The following is a description of a gene set: One-third of all estrogen receptor (ER)-positive breast tumors treated with endocrine therapy fail to respond, and the remainder is likely to relapse in the future. Almost all data on endocrine resistance has been obtained in models of invasive ductal carcinoma (IDC). However, invasive lobular carcinomas (ILC) comprise up to 15% of newly diagnosed invasive breast cancers each year and, whereas the incidence of IDC has remained relatively constant during the last 20 years, the prevalence of ILC continues to increase among postmenopausal women. We report a new model of Tamoxifen (TAM)-resistant invasive lobular breast carcinoma cells that provides novel insights into the molecular mechanisms of endocrine resistance. SUM44 cells express ER and are sensitive to the growth inhibitory effects of antiestrogens. Selection for resistance to 4-hydroxytamoxifen led to the development of the SUM44/LCCTam cell line, which exhibits decreased expression of ERalpha and increased expression of the estrogen-related receptor gamma (ERRgamma). Knockdown of ERRgamma in SUM44/LCCTam cells by siRNA restores TAM sensitivity, and overexpression of ERRgamma blocks the growth-inhibitory effects of TAM in SUM44 and MDA-MB-134 VI lobular breast cancer cells. ERRgamma-driven transcription is also increased in SUM44/LCCTam, and inhibition of activator protein 1 (AP1) can restore or enhance TAM sensitivity. These data support a role for ERRgamma/AP1 signaling in the development of TAM resistance and suggest that expression of ERRgamma may be a marker of poor TAM response. from publication Riggins RB, Lan JP, Zhu Y, Klimach U, Zwart A, Cavalli LR, Haddad BR, Chen L, Gong T, Xuan J, Ethier SP, Clarke R (PMID 18974135) Genes down-regulated SUM44/LCCTam cells (breast cancer) resistant to 4-hydroxytamoxifen relative to the parental SUM44 cells sensitive to the drug. species: Homo sapiens Human Gene Set: RIGGINS_TAMOXIFEN_RESISTANCE_DN, and this is the list of marker genes: MUC1, AOPEP, ZNF148, TNFSF10, PDE10A, NT5DC2, IFI6, SATB2, PMAIP1, UGT1A10, KIF5C, DDX60, ATP8A2, PEG10, UBXN4, LTBP3, CISH, TIMP1, DSP, ADAM9, IFIH1, PLEKHB1, CD47, CLUAP1, INSIG2, ADAM10, TM4SF1, SLC5A3, OAS1 (2'-5'-oligoadenylate synthetase 1), RANBP2, EMP1, TMEM123, SNRK, SYT1 (synaptotagmin 1), ZNF217, TFF1, FAT1, SEMA3C, SCGB2A2, UBE2L6 (NCBI Gene Id 9246), LAMP2, COMMD8, NCK2, TBC1D9, ACADM, APBB2, SP3, SERINC5, EEF1A2, EIF1AX, CREBZF, IGF1R, RBPJ, NFE2L3, RETREG1, NRCAM, NUDT4, ARFGEF1, PSD3, ISG15, ACOX2, RAPGEF2, UPF3B, NBPF14, TSPAN5, PTPN12, SERPINA5, SLC1A1, RAI14, CRYBG1, SCCPDH, DSG2, SYBU, IRF9, PHTF2, ENC1, UXS1, STC2, VPS13B, NFYB, HS2ST1, GTF2I, NMI (NCBI Gene Id 9111), MSX1, NAMPT, TESMIN, RAB31, GSAP (NCBI Gene Id 54103), PAPOLA, SLC30A9, PIK3R1, UGCG, RABGAP1L, CD302, RBMS1, PLAAT4, PDLIM5, NAT1, CTNND2, SIGLEC15, AKR1C1, NEBL (NCBI Gene Id 51739), FRYL, NEDD9, AZGP1, SCNN1A, S100A8, AKAP11, COL3A1, PMS1, SHTN1, SCARB2, LAPTM4B, ARHGAP12, CEBPD, SOX9, AP1AR, CNN3, MRPS30, NNT, APOL6, MAP3K7 (NCBI Gene Id 6885), NAB1, GTF2E1, DLG1, ALCAM, GREB1, KLF4, ARID5B, NAA15, CYP1B1, TRGC1 (NCBI Gene Id 6966), IFITM3, APOD, IL6ST, ADCY3, PALLD, ELOVL2, ATP2C2, IL17RB, TCEAL9, TMEM33, PTPN11, MYOF, UGDH, PDS5A, ESR1, TACC1, CARD10, MFAP3L, STEAP3, STC1, ZBTB18, THAP9-AS1, GJA1, CASK, EFHD1, PYGL, STAT1, NIPSNAP2, RBM47, DHRS2, IGFBP5 (insulin like growth factor binding protein 5), MXI1, IFITM2, ZFP36L1, LAP3, PPAT, DGLUCY, PDLIM3, HSPA4L, LGALS8, HMGCS1, GULP1, RPS6KA2, ABAT, CTSO, LRBA, CNR1, PLEKHA5, PLCB4, UBE2K, MAPKAPK2, MRFAP1L1, NFU1, CLK1, IFIT5, ANXA3 (NCBI Gene Id 306), BTBD3, SLC35A3, SLBP (stem-loop histone mRNA binding protein), LGALS3BP, MMP16 (matrix metallopeptidase 16), ALB, SCN1A, RAI2, WAC, KIAA0232, RAB38, SMARCA5, NPY1R, ATXN1, PRNP, UBA6, EFR3A (NCBI Gene Id 23167), CDH3, SLC39A6, CPD, BASP1, SLTM, EIF2AK2, INPP4B, CUL3 (cullin 3), CLGN, IFI27, PLCB1, DNAJC15, RGS2, VAV3, SERPINA3, CXCR4